The following is a description of a gene set: Mouse Gene Set: GOMF_ARACHIDONATE_11_12_EPOXYGENASE_ACTIVITY Catalysis of an NADPH- and oxygen-dependent reaction that converts arachidonic acid to cis-11,12-epoxyeicosatrienoic acid. studied in species Mus musculus, and this is the list of marker genes: Cyp2j6, Cyp2j8, Cyp2j9, Cyp2j11, Cyp2c23, Cyp2c38, Cyp2j13, Cyp2j7, Cyp2j5, Cyp2j12, Cyp2c39